The following is a description of a gene set: Mouse Gene Set: GOBP_EGG_ACTIVATION The process in which the egg becomes metabolically active, initiates protein and DNA synthesis and undergoes structural changes to its cortex and/or cytoplasm. species: Mus musculus, and this is the list of marker genes: Wbp2nl, Plcz1, Zp2, Nlrp5, Npr2, Tpst2, Adam24, Cast, Zp1, Camk2b, Astl, Plcb1, Myh9, Plat